Given this list of marker genes OS9, CRYAB (crystallin alpha B), SP100, RANGAP1, DDX39A, FERMT1, PKIG, ARFIP1, ABCA2, DERL3, ARHGAP8, CRYAA, SUFU, MDFIC, PKIA, HDAC3, UBE2G2, SLN (sarcolipin), SNX3 (sorting nexin 3), NFKBIA, EI24, ADIPOQ, CHP1, YOD1, RBM10, CABP1, MIR185, PCSK9, VPS35, ERLEC1, UFM1, PARK7, ARHGAP1, SIRT6, UBE2J1, CD36, ANGPT1, SUMO1, TPR, NF1, FAM76B, LRRK2, NUP153, PLN, MIR27B, TXN, MAP1B, YWHAB, BARD1, SVIP, MTMR4, RAB23, SNX12, INSIG1, MRLN, APOD, UBAC2, MIR17, DERL2, CDK5, here is a description of the gene set: Any process that stops, prevents, or reduces the frequency, rate or extent of the directed movement of substances within cells. Human Gene Set: GOBP_NEGATIVE_REGULATION_OF_INTRACELLULAR_TRANSPORT species: Homo sapiens